Given this list of marker genes Cib1, Rbm15, Jak2, Mpl, Sh2b3, Thpo, here is a description of the gene set: The series of molecular signals initiated by thrombopoietin binding to its receptor on the surface of a target cell, and ending with the regulation of a downstream cellular process, e.g. transcription. Mouse Gene Set: GOBP_THROMBOPOIETIN_MEDIATED_SIGNALING_PATHWAY studied in species Mus musculus